The following is a description of a gene set: Mouse Gene Set: REACTOME_GLYCOGEN_BREAKDOWN_GLYCOGENOLYSIS Glycogen breakdown (glycogenolysis) species: Mus musculus, and this is the list of marker genes: Calm3, Pgm1, Phka2, Phka1, Calm1, Calm2, Pygm, Akr1e1, Phkb, Gyg1, Agl, Phkg1, Gaa, Phkg2, Pygl